Given this list of marker genes PARL, AFG3L2, PMPCB, MAIP1, SPG7, YME1L1, MICU2, PHB1, MCU, PHB2 (NCBI Gene Id 11331), SMDT1, MICU1, MICU3, STOML2, PMPCA, MCUB, here is a description of the gene set: part of: Mitochondrial calcium ion transport Proteolytic processing of proSMDT1 (proEMRE) regulates assembly of properly regulated mitochondrial calcium uniporter (MCU) complex. C2orf47 (MAIP) in a complex with AFG3L2 (m-AAA protease) binds the transit peptide of proSMDT1, promotes cleavage of the transit peptide by mitochondrial processing endopeptidase, and prevents proteolytic destruction of proSMDT1. SMDT1 that is not then incorporated with the regulatory subunits MICU1 and MICU2 (or MICU1 and MICU3 in neurons) into the MCU complex is degraded by AFG3L2, preventing assembly of unregulated MCU. Unprocessed proSMDT1 is proteolyzed by YME1L1. Reactome Pathway: Processing of SMDT1 species: Homo sapiens